The following is a description of a gene set: Reactome Pathway: Glutathione conjugation species: Homo sapiens part of: Phase II - Conjugation of compounds Glutathione S-Transferases (GSTs; EC 2.5.1.18) are another major set of phase II conjugation enzymes. They can be found in the cytosol as well as being microsomal membrane-bound. Cytosolic GSTs are encoded by at least 5 gene families (alpha, mu, pi, theta and zeta GST) whereas membrane-bound enzymes are encoded by single genes. Soluble GSTs are homo- or hetero-dimeric enzymes (approximately 25KDa subunits) which can act on a wide range of endogenous and exogenous electrophiles. GSTs mediate conjugation using glutathione (GSH), a tripeptide synthesized from its precursor amino acids gamma-glutamate, cysteine and glycine. A generalized reaction is<p><b>RX + GSH -> HX + GSR</b></p>Glutathione conjugates are excreted in bile and converted to cysteine and mercapturic acid conjugates in the intestine and kidneys. GSH is the major, low molecular weight, non-protein thiol synthesized <i>de novo</i> in mammalian cells. As well as taking part in conjugation reactions, GSH also has antioxidant ability and can metabolize endogenous and exogenous compounds. The nucleophilic GSH attacks the electrophilic substrate forming a thioether bond between the cysteine residue of GSH and the electrophile. The result is generally a less reactive and more water-soluble conjugate that can be easily excreted. In some cases, GSTs can activate compounds to reactive species such as certain haloalkanes and haloalkenes. Substrates for GSTs include epoxides, alkenes and compounds with electrophilic carbon, sulfur or nitrogen centres. There are two types of conjugation reaction with glutathione: <i>displacement reactions</i> where glutathione displaces an electron-withdrawing group and <i>addition reactions</i> where glutathione is added to activated double bond structures or strained ring systems., and this is the list of marker genes: GSTM4, MGST1, CNDP2, GSTO1, GCLM, GSTT2B, GSTT1, GSTK1, GSS, GSTP1, CHAC2, GSTA1, GSTM2, GSTT2, MGST3, GSTA3, GSTM5, GGT1, GSTA4, MGST2, GSTA2, GSTM1, GGT6, GGT7, GGCT (NCBI Gene Id 79017), GGT3P, GCLC, GSTA5, GSTO2, HPGDS (NCBI Gene Id 27306), OPLAH, GSTM3, CHAC1, GGT5, ESD, GSTZ1, AKR1A1